The following is a description of a gene set: species: Homo sapiens Uptake and actions of bacterial toxins Human Gene Set: REACTOME_UPTAKE_AND_ACTIONS_OF_BACTERIAL_TOXINS, and this is the list of marker genes: CD9, SV2A, MAP2K2, SYT2, ANTXR1, SV2B, MAP2K3, SYT1, TXNRD1, ANTXR2, CALM1, MAP2K1, MAP2K6, SV2C (NCBI Gene Id 22987), VAMP1, MAP2K4, HSP90AB1 (heat shock protein 90 alpha family class B member 1), HBEGF, PDCD6IP, VAMP2, GUCY2C, MAP2K7, FURIN, NHERF4, HSP90AA1, SNAP25, STX1A, STX1B, EEF2